The following is a description of a gene set: studied in species Homo sapiens Genes containing one or more binding sites for (ATF6) in their promoter regions (TSS -1000,+100 bp) as identified by GTRD version 20.06 ChIP-seq harmonization. Human Gene Set: ATF6_TARGET_GENES from publication Yevshin I, Sharipov R, Kolmykov S, Kondrakhin Y, Kolpakov F (PMID 30445619), and this is the list of marker genes: IRF2-DT, DNAAF4, DDB2, ZNF398, STT3A, DCXR-DT, RNF11, TIMM17A, BMP4, RPS15A, ZNF446, EIF2B1, ARFGEF2, COQ8B, SF3B6, TRMT61B, DPP8, TK2, TRMT112, GPBP1L1, STK19, CATSPERG, CROCCP2, SLC35D2, MYO9A, SLC35B1, POLR1B, LINC02453, ACOT7 (acyl-CoA thioesterase 7), EXD1, CTR9, ARF3, KIZ, C16orf95, EHD4, PTPN23, MIR3677HG, CENPN, SLC35A4, RNU12, MFNG, TBC1D22B, SLC16A6, PSMA4, EFTUD2, TROAP, MSMP, IL4I1, DENND5B-AS1, DLL3, SRGAP3, AGPAT1, TRIM66 (NCBI Gene Id 9866), IPO8, MRPS35-DT, MRM3, CKLF-CMTM1, HOXA11-AS, TMEM209, ZNF180, ZNF280D, TYW1, KCTD14, RSU1, NUP155 (NCBI Gene Id 9631), ZFP91, PLCB2, GDPGP1, FUS, UQCC6, SNORD27, STARD3NL, NEAT1 (NCBI Gene Id 283131), SFN, E4F1, SCAF11 (SR-related CTD associated factor 11), H2BC5, CTDSPL2-DT, MCMBP, RPS15, HNRNPA1, PURPL, NDUFC1, LINS1, FAM133B, DCXR (NCBI Gene Id 51181), MORF4L1, AMN, ABCC3, VPS13C-DT, PDCD7, SLC38A6, CAPG, INPP5J, HEXIM2, SYNCRIP, SNRPB, CSRP1, VPS13B-DT, HOXA10-AS, TSPAN15, OXA1L-DT, ESYT2, PIGF, PRADC1, DHRS13, TMEM91, KLHDC4, SNORD1C, PRR12, SMC6, SMU1, G3BP2, SDHD, VPS13B, ANKRD13C-DT, CHD4, UEVLD, SLC27A5, BLM, NR4A2, NAPA-AS1, NDUFA5, FOXI1, ZBTB4, ERRFI1-DT, HSP90AB1, IFT122, MORF4L2-AS1, SYNGAP1, ITGB8, ZFP91-CNTF, NUFIP2, TATDN3, TMEM120A, POLR2A, USP15, AJUBA, SF3A2, CYB561A3, FCSK, NR1D1 (nuclear receptor subfamily 1 group D member 1), TBX6, MRPL24, FIS1, SLC3A2, DNAI7, TTBK2 (NCBI Gene Id 26044), ARHGAP11B-DT, NEU1, WASHC5, KIF20A, PABIR1, NCSTN, CIC, CLK1, CALU, ABHD2, HOXA11, PRPF40B, RSRP1, LINC01003, ANAPC5, KHDRBS1, SERPINB8, GATA2, TRIP4 (NCBI Gene Id 9325), HDAC9, PAFAH1B2 (NCBI Gene Id 5049), ZC2HC1C (zinc finger C2HC-type containing 1C), CSTF3, MYG1, AGBL5-AS1, COX11, APBB3, C2orf42, TBCA, TOMM22-DT, FBXW11, BBIP1, PINX1, SYS1, AP1G2, CDK4, MED20, ARHGAP19-SLIT1, GRHL2, RNF43, PIK3AP1, NAXE, EPS8, BCL2L12, SNIP1, UQCC1, NFYA, ADGRE2, RAMAC, GAU1, N4BP2L2, IVD, PIERCE2, HSPA5-DT (NCBI Gene Id 107987127), GRK6, SNUPN, KRIT1, ARID4B, RPS27L, LRRC46, TAF2, SNHG4, ASB16-AS1, ZNF341, LINC00992, MPHOSPH10, UBE2M, PRMT5-DT, ABCF1, FAM222A-AS1, RRAS, ETF1, SUCLG1 (NCBI Gene Id 8802), BAZ1B, GLS2, RNU7-27P (NCBI Gene Id 100147814), TMEM217 (transmembrane protein 217), SNORD26, PTCD1, CCSER1, MRPL2, LPXN, ENSG00000227933, MCOLN1, C2CD3, MTAP, THAP9-AS1, THSD4, LUC7L2, AGAP2-AS1, CSNK1G1, HMGCR, POLD1, SKIC3, IQGAP2, SHOC2, MPG, STEAP2-AS1, TAMM41, GABARAP, TRAF6, PHC1, DAGLB, TIMELESS, MRPL10, MATR3, MIR141, RPP25, UFL1-AS1, ANKIB1, FASTKD3, THUMPD3, CEMP1, TUT1, WBP1, ERCC5, DDX56, CTDP1-DT, CISD3, CDC23, CLASP1, ZC3H10, HMGCL, APH1A, LINC01588, RBM19, WIPI2 (WD repeat domain, phosphoinositide interacting 2), MYC (MYC proto-oncogene, bHLH transcription factor), H2AC11, IRF2, WNK4, OARD1, CETN3, MAN2C1, COX15, WDR62, SACM1L, SNORA9, C16orf46-DT, PLCD1, SERF2, TBX3, PTMS, CUL4B, TBCC, DEDD, PSMA5, AGR2, PPIP5K2, PMEL, PPP2R3B, RPS10-NUDT3, CACNA2D4, KCMF1, CCT7, ENSG00000187951, SARS2, SENP8, SEC31A, ZYX, GATA2-AS1, MMACHC, ABCC5, ROMO1, ZNF622, CBX6, MED11, DMAC2, LINC02363, FER, FAF2, TUBA1B-AS1, MALINC1, ERRFI1, FAM234B (NCBI Gene Id 57613), ATF5, TPRG1-AS1, ASXL1, DCAF12, HSPA5, C6orf226, SRSF5, FAM187A, VILL, CYCS, VDAC2, PLEKHG2, LNP1, LIMD1-AS1, SEL1L3, RNF139-DT, TMEM248, SDAD1, ZNF48, TPM2, POLK, MALSU1, BLOC1S2, BLOC1S6, NUP160, RN7SL521P, DFFB, PURA, MXI1, CENPK, GNL1, TSPAN31, FAM13B-AS1, CCNH, ATP6V1F, HSP90B1, TMEM87B, UBC, NCAPG2, RPL37, EFHB, SS18, AAAS, MDM2, DGLUCY, C19orf38, COPS7A, RMND5B, THAP8, IL23A, RBM23, CTDP1, NME1, TIA1, EFCAB5, CSRNP2, DNAAF4-CCPG1, WDR6, TNK2, C19orf25, ACTR3C, ACY1, ATP8B3, SNAPC5, GTSE1-DT, IGFL2, RABAC1, SLC25A25, NAT10, HNRNPD, C16orf95-DT, NBR1, HIGD2B, CTDSPL2, RPS19, PTP4A2, IQCG, PITRM1, MTERF1, TXLNA, RAB40B, SNHG15, GGPS1, ARSK, MIR4638, POLDIP3, H2AC3P, DAZAP2, PSMC4, ABHD5, SNX1, UFL1, SLC22A23, KCNIP2, CCNB1IP1, SRFBP1, LINC00431, TCTN1, MVK, IMMT, SZT2, SYVN1, EPOR, CIB1, SLC26A2, ZNF865, POP7, NASP, BORCS5, KMT2B, STEAP2 (STEAP2 metalloreductase), ITPKA, CUL7, A2M-AS1, DGKA, CRTC3-AS1, ASIC1, CHD9NB, BTNL8 (butyrophilin like 8), NYAP1, SUPT4H1, BAG1, AJUBA-DT, HDGFL2 (NCBI Gene Id 84717), ASB7, PRCC, TM9SF1, TMED5, SEH1L, RAB5A, TTC41P, C2CD2L, TMEM19, TOMM22, P4HA1, KIFC1, HMGB1, NSL1, SCAND1, PTRHD1, S100A14, CDKN1B, RAD51, ABCF2, MBD1, ZNF219, USE1, CMBL, TXNDC16, FBH1, USPL1, ZNF146, PRAG1, RBM4, COX6A1, STXBP4, OIP5-AS1, FBXW7, FAM131B-AS2, TMUB2, NR1H3, AP3M1, BSDC1, RIDA, CHCHD5, ANLN, YBX3, EIF4ENIF1 (NCBI Gene Id 56478), CENPO (centromere protein O), FNTB, CAV1, MPZL2, SRSF10, ZNF710, TUBA1B, TLE3, CDC42, MAILR, MIR4757, POLR3G, ZCRB1, NRSN2, ARL14EP, PCBP1, LEMD3, LOH12CR2, GRHL2-DT, ZFYVE19, MIR200CHG, MEST, B9D2, RGMB, SPDL1, SCAMP5, PLEKHG5, MAD1L1, AP2A1, TFG, LEO1, ACIN1, LRRC57, PPP1R11, MFSD8, MIR3178, RAB21, NAGK, RPS10, TARBP2, VPS33B, EMC9, DNAJC2, RPS6KA5, NAA25 (N-alpha-acetyltransferase 25, NatB auxiliary subunit), CDCA4, BRD2 (NCBI Gene Id 9803), RGMB-AS1, GTF2A2, MTREX, ACYP1, KIAA0232, IRX3, METTL25B, TMEM143, GPI, CXorf65, LINC01562, PRR3, RBM39, GSTA4, KPTN, BNIP2 (BCL2 interacting protein 2), CALCOCO1, NME1-NME2, TJAP1, RSL24D1, LRP10, XRCC1, PPIL4, TAF7, ERGIC3, TBC1D23, SEC11A, DDIT3, ERC1, CSTF3-DT, ADK, DHX29, PSMC2, PRMT5-AS1, CMC2, H2BC11, INO80C, MRPL46, PAGR1, BBS4, LNCATV, INIP, PRR13, PINX1-DT, MYO5B, CHTOP, KLHL32, REEP6, HSD17B12, SERP1, ALKBH7, RNU2-2P, AZIN1, WEE2-AS1, ALG1, RPS14, STIM2-AS1, NOSIP, ING4, TBC1D4, CCPG1, OXA1L, BTD, NR1I2, DGKI, POC5, ZNHIT1, ZDHHC12-DT, WNK1, RNF181, ARHGAP5, KLC4, RBM28 (RNA binding motif protein 28), HOOK1, SPRED1, CBLL1, RELL1, KNL1, CCDC124, RASA1, TSEN34, RRAGC-DT, DNAJC14, NBEAL1, RPL5, LTA4H (NCBI Gene Id 4048), PCBP1-AS1, CDK5, WDR74, EHD1, FAM220A, MSL1, ZNF281, LITAF, LINC01819, ING1, VTRNA1-1, PAN2 (NCBI Gene Id 9924), LINC01932, STIM2, EPB41L2, POP1, SCAMP2, ZDHHC12, RN7SL442P, MTRR, TLN2, LTBR, CYB5B, SLC25A42, GDF11 (NCBI Gene Id 10546), GAS5, RHOA, TMEM138, MED24, RPS17, H2AC8, FCHO2-DT, CLN6, FCHO2, POLD2, PLEKHF2, GFM1, ZNF652-AS1, TAF15, WDR59, ACAT2, PIGO, MRPL21, CA5B, POLL, DNAJB1, CCT2, CFTR, FLNC-AS1, ZNF557, SCFD1, DNAJB8, KRT18, WDR83, MIR5188, ZNF3, ZNF668, KALRN, PPIH, COG3, HARS1, A2ML1, NDUFA3, KDM6B, KLHL26, LDHA, AMN1, DDX55 (NCBI Gene Id 57696), MLEC, IGSF9, TBRG4, MORF4L2, GTF3C6, ENSA, NR2F1, FNBP1P1 (formin binding protein 1 pseudogene 1), NPTN, DUS2, MRPS11, TRIM41 (tripartite motif containing 41), LAPTM4A, XPO1, CCDC18, ESYT1 (NCBI Gene Id 23344), PRPF38B, LYSMD4, PTMA, PTGES3, DAXX, GLOD4, TDRKH, PDCD6IP, RAG1, FUCA1, ZNF584, MMAB, SNHG16, TOB2, RAB30, GTSE1, REXO2, EHBP1, TFCP2, PLK4, P4HB, FSIP1, PAPLN, SLC17A3, TNFSF9, MBLAC2, POLR1HASP, ENSG00000261335, PPP1R15B-AS1 (NCBI Gene Id 122455336), CEP104, MAP3K3, MEPCE, SSBP1, TMED1, CDKL3, RNF34, IRF3, TSPAN8, ISG20L2, MIR3912, AHCTF1, TRMT5, PLEKHJ1, MAGI3, EFNA3, YOD1, PSEN1, SUGP2, SNORA16A, WDR20, SMARCC2, LLPH-DT, PPP1R12A (protein phosphatase 1 regulatory subunit 12A), SH2D6, SERINC4, PCLAF, HECTD4, ETFRF1, SMARCA5, MYCBP, SYS1-DBNDD2, TMEM69, PLEKHA8, BRCA1, MRPS28, TIMM44, SNHG1, MBD6, MYL6B, KIAA0319L, INPP5F, MAZ, CSRP1-AS1, MAN1B1-DT, GGCT, KNSTRN (NCBI Gene Id 90417), AHR, IKBIP, PRIM2, USP54, DMTF1-AS1, TMBIM6, LMNA, SEC63, PIGO-AS1 (PIGO antisense RNA 1), H4C16, SREBF1, KANSL2, RPS3A, TPM3, HAUS2, LIX1L, PTPN23-DT, RHBDF1, SLC15A4, PRDX5, MBD4, TCF12, RAD52, PAIP2 (NCBI Gene Id 51247), NUP62, FLJ40288, CREBL2, PNRC2, CDC73, NCOA7, IK, PLOD3 (procollagen-lysine,2-oxoglutarate 5-dioxygenase 3), PPT2-EGFL8, PCSK4, PTBP1, PLPP6, BICRAL, EIF2AK3-DT, G3BP1, CZIB-DT, IGF2BP3, KCTD7, CRIPT (CXXC repeat containing interactor of PDZ3 domain), RNPS1, H4C2, CZIB, STX18, TMEM198B, PCAT7, BRD8, STX18-AS1, HEXIM2-AS1, SNRPE, MAST1, ZNF584-DT, ETS2-AS1, VEGFA, RABGEF1, SNORD25, EIF3G, ANKRD13C, EHMT2, RAD51-AS1, CKLF, LRCH4, MSL2, CDK5RAP1, NPM1, NRSN2-AS1, RAB30-DT, ORC2, TCP1, PRRT1, WDR12, HACL1, WARS2-AS1 (NCBI Gene Id 101929147), SYNGR4, ZNF580, ERCC6L2-AS1, ZFP62, CRTC2, DMXL2, TAOK2, ETFA, BYSL, SEC23IP, CBX5, ZNF358, TOR1AIP1, C16orf46, SETD5, MRPL1, ERCC6L2, CCDC163, CUL3, MIR3913-1, CALM2, CHPF2, TARS2, TMCO1, RHOF, MIOS, COX7C, TECR, EIF2AK3, STC2, WDR83OS, SENP1, PLA2G4E-AS1, MARS1 (methionyl-tRNA synthetase 1), CEP350, MST1P2, MKS1, GANC, H2BC8, BPGM, HYCC1, FLOT1, SART1, PCDH1, MATCAP1, TRIM52, RPS28, H4C1, ZFAND2B, RRP12, MIR5580, NDUFA2, NARS2, ITSN1, SMAGP, POT1-AS1, THUMPD3-AS1, SUMF2, CMC1, ZNF384, LRBA, B3GALNT2, SH3D21, POLG2, ABHD18, DCAF8, CUTC, DENND4A, AGBL5, HNRNPA0, HARS2, PANK3, ECI2, KITLG, CPSF4, NUTM1, OSCAR, TMEM223, PAQR4, HSD17B14, KIF21A, MGAT1, DXO, TOMM70, CCDC103, ARHGAP19, NOL3, ZBTB45, ZNF335, CERT1, ZNF565, DNAJB12, PCBP2, ADRM1, MTMR4, CHEK1, PPIL2, TNS2-AS1, XRCC3 (NCBI Gene Id 7517), RPL27A, UBE2QL1, TRIM45, COX7A2L, RTTN, RAB5B, MT1X, DPAGT1, PRMT5, TNRC6B, PLXDC1, MRPL18, TOMM40, SH2D3C (NCBI Gene Id 10044), AATF, NUMA1, AGTRAP, MIR200C, MAN1B1, ARMC6, TSFM, TYMS, COPA, ZSWIM7, ZNF770, H3-3B, MYL6B-AS1, ZBTB37, NUP153, USO1, ILRUN-AS1, FBXO24 (NCBI Gene Id 94779), SHH, TRIM39, RPL31, GPR35, TRIM37, HOXD3, SCAMP1, APAF1, PYM1 (NCBI Gene Id 84305), NOP10, EYA3, PPWD1, GTF2H3, NR2F2, TMEM87A, PRRG2, GHDC, HYPK, NAIF1, TNFRSF1A (NCBI Gene Id 8077), ACP2, DPCD, UGP2, TYMSOS, RPL35A, FKBP11, NLGN1, SNHG12, TAFA2, AKAP9, PPT2, USP22, ESRP2, NFKBID, AOAH, GLE1, ACTR3 (actin related protein 3), RNF145, NCDN, TESMIN, RSRC1, ESRP1, SEPTIN5, KIF11, RN7SK, MIR9-2HG, SIN3A (SIN3 transcription regulator family member A), DHDH, PRR29-AS1, MALAT1, IPP (intracisternal A particle-promoted polypeptide), ACTN4, GLT8D1, C6orf141, ARK2N, RPS9, TDRKH-AS1, PILRA, MBOAT7, BMF, WARS2, ENSG00000278899, SAXO5, MYL6, CHP1, DDX1 (NCBI Gene Id 1653), ARHGAP26, DCBLD1, LEKR1, ENSG00000255647, MIR5088, EEA1, ZCWPW1 (zinc finger CW-type and PWWP domain containing 1), DNAJC21, HINFP, MTMR2, INO80, TCTA, LAPTM4A-DT, NUP54, NDUFAF1, AHDC1, MIR4512, GRHPR, GPR137C, STX12, ASB8, CNPY2, NOP2, PDIA4, DCPS, SNORA44